Given this list of marker genes CYP2R1, here is a description of the gene set: Vitamin D3 (cholecalciferol), synthesised in human skin by ultraviolet radiation action on 7-dehydrocholesterol, does not possess any biological activity. Vitamin D hormonal activity requires hydroxylation at the 25 and 1-alpha positions by cytochrome P450 enzymes CYP2R1 and CYP27B1 respectively.<br>Vitamin D 25-hydroxylase (CYP2R1) catalyses the hydroxylation of vitamin D3 to calcidiol (CDL). Subsequent 1-alpha-hydroxylation of CDL produces calcitriol (CTL). CTL binds and activates the nuclear vitamin D receptor, with subsequent regulation of physiologic events such as calcium homeostasis, cellular differentiation and proliferation.<br><br>Defects in CYP2R1 can cause rickets, vitamin D-dependent 1B (VDDR1B; MIM:600081), a disorder caused by a selective deficiency of the active form of vitamin D (CTL) resulting in defective bone mineralization and clinical features of rickets. Reactome Pathway: Defective CYP27B1 causes VDDR1B part of: Metabolic disorders of biological oxidation enzymes studied in species Homo sapiens